The following is a description of a gene set: from publication Chen Y, Wang X (PMID 31504780) Mouse Gene Set: MIR_6378 Genes predicted to be targets of miRBase v22 microRNA mmu_miR_6378 in miRDB v6.0 with MirTarget v4 prediction scores > 80 (high confidence targets). studied in species Mus musculus, and this is the list of marker genes: Lpp, Cemip, Slc4a7, Slain1, Zfp319, Vmn2r89, Gfpt2, Plcb1, Pcdha12, Lipo3, Txnrd1, Abcb9, Gimap6, Rac1, Rnf11, Pcdha11, Itpr1, Grp, Apcdd1, Aqp1, Uts2b, Pcdha9 (NCBI Gene Id 192161), Rapgefl1 (NCBI Gene Id 276778), Slc19a1, Bltp3a, Polr2m, Arl8b, Pcdhac2, Odf2l, Tpi1, Cldn12, Serpini1, Irx3, Pabpc4l, Tor1b, Pcdhac1, Ugcg, Usp31, Sgcb, Srd5a1 (NCBI Gene Id 78925), Ppm1h, Pcdha1, Pcdha10, Pcdha6, Epgn, Lin28b, Ctsc, Lclat1, Pcdha4, Pou2f2, Ube3a, Zcchc12, Nsun5, Pcdha7, Zdhhc21, Stim1, Slc25a40, Otx1, Bex1, Ubap2, Atad1, Socs5, Ccnd2, Abi1, Zbtb43, Gli3, Frat2, Enox2, Sptlc1, Pcdha2, Prps1 (NCBI Gene Id 97786), Golph3, Spink11, Pcdha5, Rhbdl3, Gng2, Lars2, Slitrk5, Lrrc3b, Eef1akmt4, Fyn, Rad51c, Dcun1d4, Cntln, Pcdha3, Cep135, Krt26, Rpgrip1l, Mycbp2, Slc38a1, Pcdhb5, Ndfip2, Luc7l2, Zbtb10